Given this list of marker genes UBR5, ANAPC13, CDC27, ANAPC2 (anaphase promoting complex subunit 2), ANAPC5, HUWE1, TRAF6, ANAPC11, ANAPC10, CDC23, ANAPC1, UBR4, CDC16, ITCH, ANAPC7, ANAPC16, ANAPC15, CDC26, ANAPC4, here is a description of the gene set: species: Homo sapiens Human Gene Set: GOBP_PROTEIN_BRANCHED_POLYUBIQUITINATION A protein ubiquitination process in which ubiquitin monomers are attached to a protein, and then ubiquitin polymers are formed by linkages between lysine residues at various positions of the ubiquitin monomers, forming branched linkages, such as K11/K48- or K11/K63-linked chains.